The following is a description of a gene set: studied in species Mus musculus Mouse Gene Set: GOMF_ARRESTIN_FAMILY_PROTEIN_BINDING Binding to a member of the arrestin family, proteins involved in agonist-mediated desensitization of G protein-coupled receptors., and this is the list of marker genes: Gpr61, Itch, Drd1, Chrm2, Arrb2, Slc9a5, Gpr62, Arrb1, Ffar4, Creb1, Arrdc1, Gpr135